The following is a description of a gene set: Neighborhood of CARD15 Neighborhood of CARD15 caspase recruitment domain family, member 15 in the GNF2 expression compendium Human Gene Set: GNF2_CARD15 species: Homo sapiens, and this is the list of marker genes: PLBD1, CHST15, HK3, CASP1, SLC7A7, MFSD1, LILRB3, CTSS, DUSP6, MCL1, FPR1, MAFB, BST1, CLEC4A, CD93, CD86, CD33, S100A9, AP1S2, PSAP (NCBI Gene Id 83009), CPVL, TBXAS1, RGS2, CDA, TYROBP, LILRA2, RNF130, VNN1, PPT1, CFP, S100A4, ADA2, LST1, MNDA, APOBEC3A, FCGR1A, LILRA1, LILRA3, CD14, FGL2, CD1D, CPPED1 (calcineurin like phosphoesterase domain containing 1), STX11, TNFAIP2, CYBB, TYMP, NAIP, TLR8, VCAN, PECAM1, LILRA6, IGSF6, PILRA, AIF1, CD302 (NCBI Gene Id 9936), NCF2, CCR1, LILRB2, PYCARD, NOD2, THEMIS2, COTL1, MS4A6A, DUSP1, TLR2, SULT1A1, HCK, FCN1, TNFRSF1B, FOS